Given this list of marker genes MICAL1, NOL7, GBP1 (NCBI Gene Id 2633), C3, NME9, CCDC102B, LINC00926, STK3, MYCBP2, AKAP10, CALD1, IGLJ3, GRK3, ESR1, CYP1B1, PRPF38B, ZNF521, SKAP2, SERPINB6, DPY19L2, CFLAR, here is a description of the gene set: Genes up-regulated in microdissected endothelial samples from ovarian cancer tumors with tumor-infiltrating lymphocytes (TIL) vs those without TILs. Human Gene Set: BUCKANOVICH_T_LYMPHOCYTE_HOMING_ON_TUMOR_UP In spite of their having sufficient immunogenicity, tumor vaccines remain largely ineffective. The mechanisms underlying this lack of efficacy are still unclear. Here we report a previously undescribed mechanism by which the tumor endothelium prevents T cell homing and hinders tumor immunotherapy. Transcriptional profiling of microdissected tumor endothelial cells from human ovarian cancers revealed genes associated with the absence or presence of tumor-infiltrating lymphocytes (TILs). Overexpression of the endothelin B receptor (ET(B)R) was associated with the absence of TILs and short patient survival time. The ET(B)R inhibitor BQ-788 increased T cell adhesion to human endothelium in vitro, an effect countered by intercellular adhesion molecule-1 (ICAM-1) blockade or treatment with NO donors. In mice, ET(B)R neutralization by BQ-788 increased T cell homing to tumors; this homing required ICAM-1 and enabled tumor response to otherwise ineffective immunotherapy in vivo without changes in systemic antitumor immune response. These findings highlight a molecular mechanism with the potential to be pharmacologically manipulated to enhance the efficacy of tumor immunotherapy in humans. species: Homo sapiens from publication Buckanovich RJ, Facciabene A, Kim S, Benencia F, Sasaroli D, Balint K, Katsaros D, O'Brien-Jenkins A, Gimotty PA, Coukos G (PMID 18157142)